The following is a description of a gene set: Reactome Pathway: IRF3-mediated induction of type I IFN electronically inferred by orthology from the curated human pathway studied in species Mus musculus This event has been computationally inferred from an event that has been demonstrated in another species.<p>The inference is based on the homology mapping from PANTHER. Briefly, reactions for which all involved PhysicalEntities (in input, output and catalyst) have a mapped orthologue/paralogue (for complexes at least 75% of components must have a mapping) are inferred to the other species. part of: STING mediated induction of host immune responses, and this is the list of marker genes: Irf3, Sting1, Dtx4, Nlrp4c